The following is a description of a gene set: Human Gene Set: GOBP_REGULATION_OF_COMPLEMENT_DEPENDENT_CYTOTOXICITY studied in species Homo sapiens Any process that modulates the frequency, rate or extent of complement-dependent cytotoxicity., and this is the list of marker genes: IL10, IL4, TGFB2, CFH, CR1, CD55, IL13, CR1L (complement C3b/C4b receptor 1 like), CD5L, CD59, IL11